Given this list of marker genes SOSTDC1, BMP4 (bone morphogenetic protein 4), SULF1, SHH, BMP7, RDH10, NOG, AR, FGF10, WNT5A, FGFR2, TP63, WNT2B, CTNNB1, WNT2, here is a description of the gene set: The morphogenetic process in which a bud forms from an epithelial sheet. A bud is a protrusion that forms form the sheet by localized folding. studied in species Homo sapiens Human Gene Set: GOBP_MORPHOGENESIS_OF_AN_EPITHELIAL_BUD